Given this list of marker genes Cmpk1, Sall1, Cdk17, Rictor, Bmpr1a, Map2k1, Rfx3, Mex3c, Reep4, Pabir1, Wipi2, Akt3, Crebl2, Ube4b, Kif1c, Pth, Dixdc1, Fam135a, Eya1, N4bp1, Bicd1, Fgf7, Crebrf, Nos1, Phactr2, Smad7, Sstr3, Emc6, Zbtb39, Unc13a, Hoxd1, Polr3f, Cyp26b1, Kcnq5, Zfp622, Zfhx4, Ccne1, Rgs16, Usp2, Pam, Hspg2, Syt3, Insyn2a, Anks1, Erlin2 (NCBI Gene Id 97480), Omg, Ccnd2, Ccnd1, Kif21a, Fbxw7, 2810459M11Rik, Cpeb2, Bcl2l10, Myb (NCBI Gene Id 97674), Zfp423, Plagl1, Cacul1, Dnajc16, Reck, Socs6, Asxl3, Zfp367, Ints6l, Hectd1, Kif5c, Mgat4a, Krtap28-13, Rasgef1b, Klhl2 (NCBI Gene Id 78235), Pip4p2, Srpra, Mxd1, Kcnj2, Dclk1, Pafah1b1, Slc9b2, Nfe2l1, Prdm4, here is a description of the gene set: Mouse Gene Set: MIR_503_5P species: Mus musculus from publication Chen Y, Wang X (PMID 31504780) Genes predicted to be targets of miRBase v22 microRNA mmu_miR_503_5p in miRDB v6.0 with MirTarget v4 prediction scores > 80 (high confidence targets).